Given this list of marker genes PAK1, FBN1, DRD4, CACNB1, MTOR, TOP2B, RRAGD (NCBI Gene Id 58528), RAC1, TSHR, P2RX7, CRTC1, TRIM72, GNAI2, DDI2, CHRNG, CASP3, SCX, LYNX1, KDM1A, DRD5, MGARP, PRKCD, TREX1, VWA2, APP, RAP1BL, HTR4, INPP5K, PNPLA3, USF1, MIRLET7F1, ITGB3, EPHA4, ZBTB7B, GAB1, RGS10, TRAF2, TNS2, DRD3, PPARG, PHIP, SELENON, TLR9, DDX11, LYPD1, CRTC3, SIX1, GCG, HRAS, RGS4, AHR, LONP1, CASTOR1, ADCY6, ADIPOQ, NR1H4, DPEP1, GNRHR2, FPR2, STING1, VAMP2, RGS9, XRN1, STAT5B, IGF2, CHRNA2, ABCB1, RAPGEF2, LHCGR, PRKDC, HRH1, LPIN1, LEP, CSHL1 (NCBI Gene Id 92339), NPM1, HDAC2, SMARCC1, SORL1, CACNA1A, LARP1, PRKAA1, GNA14, G6PC1, BCAR3, CTNNB1, LY6H, PTGER1, ZNF592, HCN1, INSRR, RAB13, ARHGEF2, EEF2K, MMP3, HTR2C, NCOA5, SLC34A1, HSF1, CD36, SULT1A4, EPRS1, AKAP9, CYP11A1, GHRL, HTR2A, EDNRA, RIOK3, ROCK1, TIMELESS, SLC8A3, AQP1, HSP90B1, RIGI, PCK1, TGFB1, MAS1, FBP1, CASTOR3P, PTPN22, GABRB2, RAB10, PRNP, MIR1271, CRHBP, SLC25A33, DTNBP1, P2RX4, WT1, CPS1, SYK, PSEN1, PIP4K2A, GRIN2D, VCAM1, KCNC2, FYN, GRB10, GCLC, SCNN1A, CHRNA7, PRKCI, ACTN2, FOXO3, DNAI1, CACNA2D1, FER, AQP8 (NCBI Gene Id 343), PRKAR1A, WNT10B, ATP5F1A, JUP, ACHE, FOLR2 (folate receptor beta), GJA1, RPS6KB2, KLF2, RAPGEF1, GRM5, EPG5, PIP4K2B, ATP1A3, HTR3E, UCP2, TGM2, CHRM3, CFL1, FCGR2B, EPHB2, PDE3B, SOX9, ZDHHC7, SOCS3, GPLD1, SLC7A5, KBTBD2, PTPN1, PRKCB, ENPP1, PDK4, RAB8A, AIFM1, MAP1B, GHSR, RECQL5, CDH1, GLP1R, PKM, TYK2, STC1, ITPR1, GNA15, HDAC9, NAMPT, RAD51 (NCBI Gene Id 5888), PIK3CA, FUT7, CSRP3, MAPK1, ECHDC3, CASTOR2, PKD2 (polycystin 2, transient receptor potential cation channel), GRK2, RALB, DAXX, WNT1, GNRHR, ADRB2, BACE1, HDAC5, JAK1, HRH3, AHCYL1, SLIT2, TLR6 (toll like receptor 6), TIFAB, SRD5A1, SLC30A10, CYP11B1 (NCBI Gene Id 1584), NONO, KLF4, PDPK1, ACE, SIK2, NHERF1, SYAP1, GCK (NCBI Gene Id 2645), RTF2, HTR2B, APC, SAMTOR, GH1, PRKCQ, IFIT1, INS, CSH1, CFTR, CTSD, MAT2A, SGCB, CPEB2, YWHAG, PDE12, LEPROT, CHRNA1, IRS1, SLC8A1, CREB1, BRCA1 (NCBI Gene Id 672), AMIGO1, CCNA2 (NCBI Gene Id 890), FOXO4, NCSTN (NCBI Gene Id 57297), LGMN, BCAR1, AGER (NCBI Gene Id 177), SNX6, UMODL1, MIR17, SLC5A5, SLC27A4, VPS35, EDN1, CTNNA1, JAK3, PIK3R1, NOD2, NCOA1, AFG3L2, FOXC2, OAS1, RB1, RYR2, P2RX3, LARGE1, LY6E, SELENOS, DHX9, CHRNA3, PPP1R9B, CHRM4, TOP1, FAT1, P2RY11, SCNN1B, BLM, IRF3, CHRNB4, RAPGEF3, DRD1, PARP1, PIK3CG, UROS, AGTRAP, RAB31, RYR1, SESN1, GNAL, ADCY8, NCOA2, RAP1A, NR4A1 (NCBI Gene Id 93352), DDR2, GNB5, CRH, JAK2, MAP3K5, P2RY4, HTR3B, CRKL, MTR, LDOC1, CHRM5, STAMBPL1, GATA5, INHBB, NR4A3 (NCBI Gene Id 8013), MIR107, IFNB1, CYBA, AQP9, VIM, P2RY1, MAP3K7, OPRM1 (NCBI Gene Id 4988), IFIH1, CDK5, ABL1, GABRB3, CGAS, RBX1, HTR3A, PRKCZ, MSTN, AGT, SERPINA12, ATRX, TRPM4 (transient receptor potential cation channel subfamily M member 4), CHRM2, LY6G6D, MIR145, IL1B, GSTP1, KCNQ1, RPS6KB1, USO1, GHR, NPR2, STAT6, INSIG1, EP300, GATA1, INSIG2, MYO5A, RPL23, BCL11A, EZH2, SOCS2, NDEL1, AKT1, IRS4, CUL3, MIR143, HCN3, CRK, NKX6-1, CA2, GRIN1, SOS2, SH2B2, TLR4, KLF16, GKAP1, HTR7, HPCA, GNAO1, NGFR, NFKB1, ATP2B1, HTR3D, GRIA1, SREBF1, PTPRE, TREM2, CEACAM1, NFE2L2, PRKCA (NCBI Gene Id 5578), GCGR, KANK1, SIRT1, PRKN, ABCC1, CHRNE, AP3S1, EIF4EBP2, HTR1B, PID1, CSF2RA, LPIN2, TP53, AKAP7 (A-kinase anchoring protein 7), SULT1A3, IGFBP1, SESN3, SNX5 (sorting nexin 5), STXBP4, CRHR1, OAS3, FLNA, GNG2, GNAS, GCLM, STAT1, ATP2B4, XBP1, CHRNB2, MIR140, CFLAR, SCNN1D, ROCK2, FUT1, FOS, SLC9A1, TSC2, TAF1, IRF5, CACNA2D3, CHRNA4, PIK3R3, TMEM38B, SOCS7, NSMCE3 (NCBI Gene Id 56160), NR4A2, IDE, CASP7 (NCBI Gene Id 840), RAF1, CAMK2A, NTRK1, PENK, FDX1, GABRB1, TRIM41, IRS2, SLURP2, ALK, LARS1, C2CD5, MIR195, HNF4A, CYBB, UBR2, LRP1, KLHL22, SOCS1, GPR173, PRKD1, GSK3B, PLCB1, SLC2A4 (solute carrier family 2 member 4), ITGA4, KCNE1, NCL, GSK3A, CPEB1, AKAP6, AANAT, HTR3C, GNB1, PSCA, PTPRJ, FOLR1, GRB14, LPIN3, CHRND, ZFP36L1, SLC26A6, SPIDR, SLC2A8, PPP3CA (NCBI Gene Id 5530), CASP4, CHRM1, FLOT1, SRSF5, IGF1, POR, CDK2, UBR1, TRPV1 (NCBI Gene Id 7442), PDK2, SIN3A, LEPROTL1, NOD1, MEF2C, GDF15, ATP5PO, BLVRB, PIP4K2C, CHMP5, SP1, RBM4, ZNF106, PCSK9, GRIN2A, MIR103A1, SLC26A3, AGTR2 (angiotensin II receptor type 2), APPL1, POU4F2, GRB7, ERRFI1, RHOQ (ras homolog family member Q), MYO1C, ABCC9, TMEM38A, GPER1, CRHR2, SHC1, EZR, MBD5, HTR1A, P2RY2, SESN2, FAM114A1, AGRN, ACTB, CASP6, RELA, GH2, LY6S, SSH1, CRTC2, CHRNA10, GPD1, DMTN (NCBI Gene Id 2039), GSTM2, PLA2G2A, PIK3R2, ADCY5, CASQ2, IGFBP5, GRB2, CHRNB1, PRMT5, CSH2, PKLR, ADIPOR1, SLC27A1, COL6A1, LYN (LYN proto-oncogene, Src family tyrosine kinase), C14orf28, TBC1D4, CAV2, PRMT1, PALM, MTCL2, OTOP1, DRD2, COMT, SOS1 (SOS Ras/Rac guanine nucleotide exchange factor 1), KAT2B, ITPR2, APLP1, HRH4, AHSG, CHRNB3, DIAPH1, SLC6A4 (NCBI Gene Id 6532), RPTOR, DEFB124, SORBS1, WDTC1, DDI1, FOXO1, RIPK2 (receptor interacting serine/threonine kinase 2), TLR3, CACNA1S, FBXW8, GOT1, PTPN11, HTR6, CUL7, SLC39A14, LRRK2, GLP2R, PPP1R1B, DENND4C, AKT2, GABRG2, RGS8, INSR, SLC1A1, NPPC, BAIAP2 (NCBI Gene Id 10458), ERFE, GNAQ, NPPA, TRARG1, GNA11, FFAR3, SLC1A2, AGTR1, SHMT1, SLC1A3, EHMT2, SCNN1G (NCBI Gene Id 6340), RAP1B, CDK5R1, TRPA1, STAT5A, PDE2A, GUCY1B1, CIB2 (NCBI Gene Id 404086), MAPK3, MIR146A, PDE3A, ZCCHC3, TNF, OSBPL8, ICAM1, PIK3C2A, GHRHR, OGT, MDM2, NCK1, CYP11B2, IGF1R, BGLAP, CAMP, LCN2 (NCBI Gene Id 3934), CSK, SLC22A12, GPR21, CDC6, MIR106B, MIR200A, P2RY6, P2RY12, CHRNA5, PDE4D, CAPN10, ARRB2, HCN2, MIR98, PCK2, GOLPH3, RARRES2, STAT3, TYROBP (transmembrane immune signaling adaptor TYROBP), HNRNPD, INHBA, CHRNA6, PDXP, MAPKAP1, ALAS1, RANGAP1, TRIB3, SRC, HCN4, RAP1GDS1, CHRNA9, CAV1, SOD1, PLA2G1B, C1QTNF12 (C1q and TNF related 12), MAVS, MUL1, EGR1, APPL2, SHOC2, PTK2, PRKACA, MIR15B, PQBP1, RYR3, NUCKS1, COLEC12, PXN, BCL2L1, MZB1, PTPN2, HMGCS2, ASS1, here is a description of the gene set: species: Homo sapiens Any process that results in a change in state or activity of a cell (in terms of movement, secretion, enzyme production, gene expression, etc.) as a result of a nitrogen compound stimulus. Human Gene Set: GOBP_CELLULAR_RESPONSE_TO_NITROGEN_COMPOUND